The following is a description of a gene set: The receptor clustering process in which gamma-aminobutyric acid (GABA) receptors are localized to distinct domains in the cell membrane. Human Gene Set: GOBP_GAMMA_AMINOBUTYRIC_ACID_RECEPTOR_CLUSTERING species: Homo sapiens, and this is the list of marker genes: LHFPL4, GLRB, GPHN (gephyrin), SHISA7, NRXN1